The following is a description of a gene set: species: Homo sapiens Cerebral inclusion bodies Human Gene Set: HP_CEREBRAL_INCLUSION_BODIES Nuclear or cytoplasmic aggregates of stainable substances within cells of the brain., and this is the list of marker genes: LRRK2, NPC2, GIGYF2, ATXN2, PSEN1, PLA2G6, TMEM106B, TREM2, APP, C19orf12, NOS3, ADH1C, SNCB, PLAU, VPS35, ATXN8OS, GBA1, SNCAIP, HNRNPA1, GRN, APOE, EIF4G1, NHLRC1, MPO, TOMM40, RAB39B, PRKN, PRDM8, TIA1, CYLD, DNAJC13, PRNP, ATXN3, FMR1, GFAP, VPS13C, NR4A2, ABCA7, TBP, SNORD118, PSEN2, EPM2A, VCP, MT-TT, HNRNPA2B1, MAPT, SORL1, FBXO7, SNCA, ITM2B, CHMP2B, NPC1